The following is a description of a gene set: studied in species Homo sapiens Human Gene Set: GSE339_CD4POS_VS_CD8POS_DC_UP Genes up-regulated in comparison of CD4 dendritic cells (DC) versus CD8 DCs. from publication Edwards AD, Chaussabel D, Tomlinson S, Schulz O, Sher A, Reis e Sousa C (PMID 12816982) The functional relationships and properties of different sub-types of dendritic cells (DC) remain largely undefined. We used a global gene profiling approach to determine gene expression patterns among murine splenic CD11c high DC subsets in an effort to better characterise these cells., and this is the list of marker genes: KLK8, RNF166, ACTN2, PTPN22, MAN1A1, USP2, BBS9, ABCB1, TGM2, RGS3, CRNKL1, TRAF3, ROCK2, FRMD5, SDSL, ATP2A3, GLUD1, SAA1, ENO3, FH, PRM3, KLF10, USP18, NAV1, MTMR9, RIPOR2, VEGFA, GART, EXOSC10, COL13A1, POLA1, PNPO, LCP2, TNNI3, WASHC2A, AMBRA1, ARHGAP9, CPSF2, IL2RG, HLA-DOA, UBQLN1, NNT, SLC4A1AP, KANSL2, CCR6, RHOA, LAT2, NFKB1, CTSA (cathepsin A), UHMK1, ASCL2, FOLR2, VOPP1, RELB, MAP2K1, HGSNAT, BANP, SOX13, APOBEC1, CYFIP1, HRH1, RAB24, MAP3K3, SLC38A2, PPP1R17, SESN1, ACAD9, ANGEL2, NDUFA12, RGS14, PLTP, RNF181, FAM13B, BHLHE40 (basic helix-loop-helix family member e40), EZH1, NLRX1, CTC1, SMIM14, PHF12, IL6R, LPIN2, SLC2A3, NR4A1, API5, LASP1, PLXND1, MMP12, GGH, CHKA, TMEM268, ANP32A (NCBI Gene Id 8125), SMAD7, PTPRB, LTA4H, PTS, TUBGCP3, RYR3, ULK2, CIB1, IPP, SYT2, CLPTM1 (CLPTM1 regulator of GABA type A receptor forward trafficking), LTB, CD164, SEMA7A, MARVELD1, TLR6, MAST3, TRAF1, RASAL3, STK38, BIN1, VPS26B, CCNF, HSD17B8, FAM107B, GOSR2, ICAM2, BMPR2, GALNT1, B4GALNT1, MYO1B, FAM32A, ABCF3, IFITM2, CCRL2, TSPAN9, EMB, FCER1G, TNFRSF19, BCL10, HOXA7, NAA60, PAX3 (paired box 3), PTPN12, EMP3, MARS1, NPC1, CDK7, CCL4, MNS1, ACP2, PLXNB2, RAC2, TCF25, SHISA5, DALRD3, KRTAP19-5, RPS6KA4, EIF2S3, KDM5B, FGR, ABCA2 (ATP binding cassette subfamily A member 2), RHOH (ras homolog family member H), NOG, HIC1, SMARCA2, GCNT1, MAPK14, DLG1, SEC62, PPIL2, IL1R1, FBXO8, HDC, DCAF8, TNFRSF1B, HOXA5, CD300C, SAMHD1, PTGS2, GOT2, PRKACB, ARL4C, SATB1, TNFRSF11A, ETNK1, PPP2R5D, ARHGEF3, LBR, AEBP2, SERPINI1, SLC6A13, CD72, PTPN6, RASSF5, PITPNB, BCL3, CCDC80, FGF5, DHRS3, IPO7, UBQLN2, MYO1F, TPM2, B4GALT6, DIAPH1, TEP1, LY9, RGL1